Given this list of marker genes DCAF7 (DDB1 and CUL4 associated factor 7), CAND1, ASB5, UBE2M, UBXN7, KEAP1, COPS7B, PSMA7 (NCBI Gene Id 5688), FBXO15, PSMD1, ASB2, SENP8, CDKN1A, DTL, KBTBD8, DCAF13 (NCBI Gene Id 29069), HIF1A, ASB1, SPSB2, COPS7A, FBXW12, SOCS2, BTBD6, RBBP5, ASB8, CUL3, RNF7, ASB18, PSMA2, FBXW2, PSMD2, UBC, DCAF10, COMMD1, WDR5, HIF3A, COPS8, PSMB5, FBXO4, FBXL18, LRRC41, PSMD11, NFE2L2, KLHL3, COPS5, KLHL42, KCTD7, FBXL3 (NCBI Gene Id 26224, F-box and leucine rich repeat protein 3), PSMD3, VCP, PSMD12 (proteasome 26S subunit, non-ATPase 12), FBXL7, ERCC8, COMMD6, PSMD7, COPS4, COPS6, COP1 (COP1 E3 ubiquitin ligase), BTBD1, ASB9, WSB2, PSMC2, SPSB3, FBXL5, COMMD4, ASB15, ASB3, EPAS1, AMER1, FBXO30, CUL4B, FBXO31, KBTBD13, PSMB3, BTRC, DDB1 (damage specific DNA binding protein 1), ASB17, DCUN1D2, GPS1, COMMD10, FBXO7, FBXL14, ASB7, DCUN1D5, PSMB2, KBTBD6, FBXL15, RPS27A, FBXL21P (NCBI Gene Id 26223), FBXO44, FBXO21, PSMD13, PSMA3, CUL5, SOCS3, DCUN1D3, UBA3, PSMB4, SKP2, CUL4A, COMMD8, FBXW9, CCDC8, FBXW11, LRR1, FBXO6, SEM1, ELOC, CISH, KLHL9, ANKRD9, NAE1, DDA1 (DET1 and DDB1 associated 1), FBXL19, UBE2D2, ASB4, PALB2, CUL9, DCAF4, SPSB1, KLHL13, FBXO40, FEM1A, NPLOC4, COPS3, PSMA5, CUL7, FBXL8, RBX1, PSMC4, NEDD8, SKP1, COMMD3, FBXW7, DCUN1D1, TULP4, VHL, ZBTB16, LMO7, COPS2 (COP9 signalosome subunit 2), ASB10, ADRM1, PSMD14, FBXL20, ASB16, FBXO32, FBXL13, PSMA4, UBE2F, SQSTM1 (NCBI Gene Id 94002), FBXO2, FBXO27, KBTBD7, ASB6, ELOB, FBXL22, UFD1, FEM1C (NCBI Gene Id 84463), DDB2, UBD, MUL1, PSMD6, ASB12, FBXO10, FBXW4, DPP3, DCAF16 (DDB1 and CUL4 associated factor 16), PSMC1 (proteasome 26S subunit, ATPase 1, NCBI Gene Id 5700), PSMB6, CUL1, COMMD5, KLHL21, FBXL12, PSMD8, NUB1, FBXW10, KCTD6, KLHL25, FBXO22, SOCS5, WSB1, PSMC3, BRCA1, FBXW8, PUM2, RBBP7, PSMB1, FBXO41, KLHL20, PSMA6, GAN, WDTC1, PSMA1, KLHL22, KLHL2, ASB11, PSMC5, COMMD9, OBSL1, KLHL41, SOCS6, CUL2, BIRC5, KLHL5, NEURL2, ASB13 (NCBI Gene Id 79754), DCAF11, FEM1B, DCAF5, COMMD2 (COMM domain containing 2), UBE2D3, PSMB7, DCAF8, DCAF6, CCNF, ASB14, DCUN1D4, FBXO11, X, FBXO17, FBXO9, KLHL11, UBB, UBE2D1, UBA52, FBXW5, FBXL4, CCDC22, SPSB4, UCHL3, FBXL16, COMMD7, DCAF17, PSMC6, here is a description of the gene set: studied in species Homo sapiens NEDD8 is a small ubiquitin-like molecule that is conjugated to substrate proteins through an E1 to E3 enzyme cascade similar to that for ubiquitin. The best characterized target of neddylation is the cullin scaffold subunit of cullin-RING E3 ubiquitin ligases (CRLs), which themselves target numerous cellular proteins for degradation by the proteasome. The multisubunit CRL complexes are compositionally diverse, but each contains a scaffolding cullin protein (CUL1, 2, 3, 4A, 4B, 5, 7 or 9) and a RING box-containing E3 ligase subunit RBX, along with other adaptor and substrate-interacting subunits. RBX2 (also known as RNF7) interacts preferentially with CUL5, while RBX1 is the primary E3 for most other cullin family members. Neddylation of the cullin subunit increases the ubiquitination activity of the CRL complex. In addition to CRL complexes, a number of other less-well characterized NEDD8 targets have been identified. These include other E3 ubiquitin ligases such as SMURF1 and MDM2, receptor tyrosine kinases such as EGFR and TGF beta RII, and proteins that contribute to transcriptional regulation, among others. <br>Like ubiquitin, NEDD8 undergoes post-translational processing to generate the mature form. UCHL3- or SENP8-mediated proteolysis removes the C-terminal 5 amino acids of NEDD8, generating a novel C-terminal glycine residue for conjugation to the cysteine residues in the E1, E2 enzymes or lysine residues in the substrate protein, usually the E3 NEDD8 ligase itself. Most substrates in vivo appear to be singly neddylated on one or more lysine residues, but NEDD8 chains have been formed on cullin substrates in vitro and on histone H4 in cultured human cells after DNA damage. The significance of NEDD8 chains is still not clear. <br>NEDD8 has a single heterodimeric E1 enzyme, consisting of NAE1 (also known as APPBP1) and UBA3, and two E2 enzymes, UBE2M and UBE2F, which are N-terminally acetylated. All NEDD8 E3 enzymes reported to date also function as E3 ubiquitin ligases, and most belong to the RING domain class. The best characterized NEDD8 E3 enzymes are the CRL complexes described above. RBX1-containing complexes interact preferentially with UBE2M, while UBE2F is the E2 for RBX2-containing complexes. <br>Neddylation is regulated in vivo by interaction with DCUN1D proteins (also called DCNLs). The 5 human DCUN1D proteins interact both with cullins and with the NEDD8 E2 proteins and thereby increase the kinetic efficiency of neddylation. Glomulin (GLMN) is another regulator of CRL function that binds to the neddylated cullin and competitively inhibits interaction with the ubiquitin E2 enzyme.<br>The multisubunit COP9 signalosome is the only cullin deneddylase, while SENP8 (also known as DEN1) contributes to deneddylation of other non-cullin NEDD8 targets. In the deneddylated state, cullins bind to CAND1 (cullin associated NEDD8-dissociated protein1), which displaces the COP9 signalosome and promotes the exchange of the ubiquitin substrate-specific adaptor. This allows CRL complexes to be reconfigured to target other subtrates for ubiquitination.<br><br> Reactome Pathway: Neddylation part of: Post-translational protein modification